Given this list of marker genes SLC18A2, SLC18A3, SLC18A1, SLC29A4, SLC6A4, SLC22A2, SLC18B1, SLC22A1, SLC22A3, SLC29A3, SLC6A2, SLC6A3, here is a description of the gene set: Human Gene Set: GOMF_MONOAMINE_TRANSMEMBRANE_TRANSPORTER_ACTIVITY studied in species Homo sapiens Enables the transfer of monoamines, organic compounds that contain one amino group that is connected to an aromatic ring by an ethylene group (-CH2-CH2-), from one side of a membrane to the other.